Given this list of marker genes SERPINE1, EFNB3, GZMA, TCF15, SEL1L, UTS2R, TRGC1, CCN1, MLLT11, PPIE, CKB, PDIA6, PGK2, GATA4, CNR1, IL1A, METTL3, KLF10, MYT1L (NCBI Gene Id 4662), PVALB (parvalbumin), CANX (calnexin), FABP4, VCAM1, LCN2, NUPR1, TUBA3D, HLA-B, TOB1, KRT17, here is a description of the gene set: Human Gene Set: PAL_PRMT5_TARGETS_DN from publication Pal S, Vishwanath SN, Erdjument-Bromage H, Tempst P, Sif S (PMID 15485929) Genes down-regulated in NIH-3T3 cells (fibroblast) after knockdown of PRMT5 by RNAi. Protein arginine methyltransferases (PRMTs) have been implicated in transcriptional activation and repression, but their role in controlling cell growth and proliferation remains obscure. We have recently shown that PRMT5 can interact with flag-tagged BRG1- and hBRM-based hSWI/SNF chromatin remodelers and that both complexes can specifically methylate histones H3 and H4. Here we report that PRMT5 can be found in association with endogenous hSWI/SNF complexes, which can methylate H3 and H4 N-terminal tails, and show that H3 arginine 8 and H4 arginine 3 are preferred sites of methylation by recombinant and hSWI/SNF-associated PRMT5. To elucidate the role played by PRMT5 in gene regulation, we have established a PRMT5 antisense cell line and determined by microarray analysis that more genes are derepressed when PRMT5 levels are reduced. Among the affected genes, we show that suppressor of tumorigenicity 7 (ST7) and nonmetastatic 23 (NM23) are direct targets of PRMT5-containing BRG1 and hBRM complexes. Furthermore, we demonstrate that expression of ST7 and NM23 is reduced in a cell line that overexpresses PRMT5 and that this decrease in expression correlates with H3R8 methylation, H3K9 deacetylation, and increased transformation of NIH 3T3 cells. These findings suggest that the BRG1- and hBRM-associated PRMT5 regulates cell growth and proliferation by controlling expression of genes involved in tumor suppression. species: Mus musculus